The following is a description of a gene set: Genes containing one or more binding sites for (Sall1) in their promoter regions (TSS -1000,+100 bp) as identified by GTRD version 20.06 ChIP-seq harmonization. Mouse Gene Set: SALL1_TARGET_GENES species: Mus musculus from publication Yevshin I, Sharipov R, Kolmykov S, Kondrakhin Y, Kolpakov F (PMID 30445619), and this is the list of marker genes: Gm5464, Vwc2l, Gm14017, Kcnq1ot1, Pde4d, H2ac5-ps, Alyref2, Creb1, Zfp949, Gm22661, Cdkl3, Mir1956, Dppa5a, Setd5, Etv5, Yif1b, Shisa2, Gm28513, B230307C23Rik, Dock9, 1700019D03Rik, Cdk5r1 (NCBI Gene Id 52900), Sall4, Dusp6, Cped1, Hprt1, 1700008O03Rik, Tbc1d23, Fam193a, Gm15290, Magohb, Sucla2, Gm5700, Zfp42, Trio, Gm25152, Gm11627, Pcdhga6, Gm12100, Stum, Fbxo11, Dennd2c, Zfyve9, Ankrd55, Gm15226 (NCBI Gene Id 100041912), Oxct1as, Mbd5, Ncam1, Zfp521, Zfp512, Apela, Srgap3, Zfp600, Kif20b, Mcm6, Smim27, Arid1a, Wdtc1, Gm20609, Cpeb3, Trpm7, Glo1-ps, Prickle1, Pfdn4, Tfdp2, Agk, Slco5a1, Got2, Mtus1, A530020G20Rik, Eci2, Snai2, Nupr1, Zfp608 (zinc finger protein 608), Tubg2, Neil3, Scp2, Gm10044, Art5, Slc25a40, Axl, Pax6, Psmd13, Cdh10, Ddx59, Hnrnpu, Rdm1, Parvaos (parvin, alpha, opposite strand), Cab39, Btf3l4, Commd2, Scg2, Bcl9, Gm12320, Fis1, Tbc1d9b, Tcf4 (transcription factor 4, NCBI Gene Id 67762), Altre, Ankrd35, Zbtb38, Usp44, Ankrd40, Rangap1, Txlnb, Casz1, Rpl5, Mir1894, Zfp516, Leo1, Plekha1, Slc25a5, Fundc2, Rimoc1, Spmip7, Qdpr, Lmbrd1, Fbxo36, Clec2d, Cyp2j6, Atp5mc1 (NCBI Gene Id 11951), Pnpla8, Fndc3a, Ucp2, Pxk, Rbm47, Wnk3, Nqo1, Gm22788, Rnf125, Olig3, Wls, Ift46, 4930453N24Rik, AI115009, Atad2b, Vldlr, Kat6a, Rif1, Adgra2, Fut10, Dnpep, Afg1l, Abcg2, Fsbp, Slc13a2, Smarcd3, Tgif1, Zfp148, Zfp760, H3c2, Arl6ip5, Ldha, Tenm3, Sh3tc1, Zfp568, Tyro3, Cenpb, Hsp90aa1, Gys1, Gm8596, Gm12676, Zfp182, Slc43a1, Fubp1, Cep41, Mir7671, Ambra1, Meis2, Spp1, Mir6352, Gm23946, Plcxd3, Wnk1, Frmd4b, Prrc2a, Gm11518, Tnfrsf11a, 5830487J09Rik, Atf6, Kics2, Gm26907, Gm15706, Gm650 (predicted pseudogene 650), Tcea3, Utp14b, Cox7a1 (NCBI Gene Id 12865), Rnu1b2, Trip4, Dapp1, Cast, Elavl4, Irak2, Gm11346, Prrt1b, Apc, Cog3, Atp7a, Shb, Gm11827, Ccdc162, Map4, Eif4e, Lmo1, Tjp2, Prune1, Sox2ot, Phc1, Npc1, Slf2, Mir6380, Slc12a2, Snx17, Itpka, Ercc4, Mast2, Eml5, Cpsf6, Gm11198, Gm12366, Tomm40l, Chd9, Stxbp3 (syntaxin binding protein 3), Gnai2, Morc2b, Slc35f2, Nfia, Itga6, Slc8b1, Atxn7l1 (ataxin 7-like 1), Usp7, B230112J18Rik, Vkorc1, Snora61, Dpysl3, Tmbim4, Fam185a, Gm13586, Nr5a2, 4930445N18Rik, Sfrp1, Chrna9, Nid2, Klhl5, AA474408, Eddm13, Evi5, Htr2b, 1700021F02Rik, Hpgd, Eif3e, Abca8b, Glrx2, Klf3, Zbtb18, Fcor, Jade1, 4921514A10Rik, AW551984 (NCBI Gene Id 244810), 4930535E02Rik, Prr13, Elobl, D830025C05Rik, Tti2, Spats2l, Mir367, Dnah14 (NCBI Gene Id 381311), Trim13, Hook2, Eif4g1, Stmn1, Pot1a (NCBI Gene Id 69016), Mrpl13, Tanc1, Polg, A930012O16Rik, Dst, Ppp1r2-ps1, Sh3gl1, Pml, Acox1, Ifit2, Gm53, Camk1d, Ppp1cc, Hormad2, Ticrr, Gm6283, 1700020L13Rik, Atg14, Gabpb2, Arf4 (NCBI Gene Id 30916), Dcp1b, Ackr3, Mxi1, Mrpl39, Fbxo15, 3222401L13Rik, Bcl6, Mrpl11, Mbnl1, Gm20604, Gm867, Tmem253 (transmembrane protein 253), Ripk1, Zfp958, Sec24b, Gm23613, Rsrc1, Tmsb10, Pcmtd1, Mnat1, Abcc10, Yars2, Cand1, Ylpm1, Sp3, Gnpnat1, Vegfc, Hscb, Fetub, Prp2rt, Slc25a53, Mettl2, Apold1, Prmt6, Tbx3, Lmo4, Ston1, Tmem220, Ccnc, Mir302a, Prorsd1 (prolyl-tRNA synthetase domain containing 1), Nt5m, Apoo, Gm22779, Rbmx2, Sertad2, Rras, Gm20655, Med18, A730036I17Rik, Mras (NCBI Gene Id 73053), Setd2, 2410137M14Rik, Gm11335, Rbbp7, Phip, Ptch1, Rpe, Nf1, 9530068E07Rik, Emx2, Gm23596, Rev3l, Cilk1, Clcn3, AU040972, 2210417A02Rik, Elapor1, H2-T24, Upp1, Mir125b-1, Peg10, Trp53cor1, Atp9a, Urgcp (NCBI Gene Id 72046), Slc25a12, Rpgrip1, Mab21l3, Magt1, Maf (NCBI Gene Id 78336), Pds5a, Pelp1, Mir302d, Mylpf, Nop58, Foxp1, Gm26562 (NCBI Gene Id 105246095), Mtf2, Rapgef2, Rmc1, Anapc5, Hsp90ab1, Prdm1, Mindy2, C1rl, 1700023G09Rik, Platr14, Mir6347, Zdhhc18, Zfp595, Rabgap1l, Atp10d, Nrip1 (nuclear receptor interacting protein 1), Dppa4, Pdgfd, Snhg12, Slc12a6, 9030622O22Rik, Clec12a, Gm17057 (predicted gene 17057), U2surp, Gprc5a, Suco, Ank2, Tns3, Dusp19, Hoxaas3, Smim18, Fbxo5, Efna1, Cntnap3, Tmem11, Tmem131l, Cripto, Ak4, Gm26901, 4930439D14Rik, Gas2, H2ac11, Ect2, Pdzk1, Rbpj, Prmt3, Cop1, Dhx57, N4bp2l2, Ywhah, Polr3g, 1700010H22Rik, Ppp3r1, 2700038G22Rik, Elovl6, Plekhb1, Rsl24d1, Ccdc68, Abl2, Mat2b, 9330185C12Rik, Shcbp1l, Bard1, Pikfyve, Plcb4, Gm12059, Vps50, 2310069B03Rik, Gm26703, Esrrb, Mpc1, Pus10, Gm13474, Luc7l2, B530045E10Rik, Platr22, Atg13, Hmgn2-ps, Hus1, Usp22 (ubiquitin specific peptidase 22), Rnf8, Tpd52, Psmc6, Gm9050 (predicted gene 9050), F13b, Trav6-3, Sh3bgrl, Avl9, Mlh3, Sbds, Slc30a7, Frem1, Cops7b, Gsr, Mpzl1, Rpf1, Tcf7l2, Gm14210, Tmem38b, Pard3, Rerg, Tbc1d4, Setdb1, Syndig1, 1700071M16Rik, Tyw1, Gm13349, Asxl1, Skida1, Ifitm1 (NCBI Gene Id 68713), Sash1, Scarna2, Gm12795, Mup6, Tdh, Npm3-ps1, Kis2, Pex13, Tnfaip6, Tbrg1, Zfp3, 4833439L19Rik, Cox16, Armcx1, Snurf, 2900041M22Rik, Aim2 (NCBI Gene Id 383619), Ptprz1, Slc29a1, Gm8210, Zfp207, Gm24031, Gm3329, Sec61a2, Gm4984, Porcn, Gm16551, Cebpzos, Tnnt1, Apol7a, Arl14ep, Akr1c19, Gfer, Mir124a-1hg, Smarca5, Slc23a2, Tuba1b, Btf3-ps2, Ctbp2, Spag9, Nrg4, Borcs5, Med1, Armc9, Dhx32, Egfros (epidermal growth factor receptor, opposite strand), Mkrn2, Zfp74, Mir9-2, Ppp1r9a, Trerf1, F8, Pbx2, Gm12974, Gm26744, Elf1, Gid8 (NCBI Gene Id 98980), H60b, Gm11517, Clk4, Plet1, Bcat1, Col25a1, Tmed7, Zfp710, Marf1, Ndst3, Nfyc, Fh1, Slc35d2, Ccdc177, Sox11, Nuggc, Platr10, Ino80dos, Or8b49, 2410021H03Rik, Tm2d1, Actl6a, 2010204K13Rik, Cdiptos, Rarg, Ncor1, Gm11960, Otop1, Epb41l5, Gm10224, Ank3, Gimap9 (GTPase, IMAP family member 9), Gm17501, Tle4, Sycp2l, Arhgef12, Trim6, Slc37a2, Atg2a, Halr1, BC048507, H2ac8, Rnf157, Sms, Ubqln2, Lrp2, Clcc1, Impa2, Ubb, Trim34b, Mdm4, Lockd, Ttc33, Snord3b-ps2, Ino80d, Eps15, Dlg1, Angpt2, Gm4895, Slc6a6, Rpl24, Ipo11, Itpk1, Rev1, Gm19710, Pttg1, Aasdh, Fbln5, Zmym1, Pabpc4, H3c11, L1td1, Usf3, Akt3, Mir3098, Mcm5, Pcdhgb5, Gm2541, Hnrnpdl, Dab2ip, Xpa, BC004004, Otud5 (NCBI Gene Id 54644), Mcc, Dtl, Gm11496, Arpc3 (actin related protein 2/3 complex, subunit 3), Pfkfb4, Clk1, Zfp791, Kras, Dbf4, Abt1, Fbxl17, Xkr8, Dcun1d3, Rny3, Rps23rg1, Mogat1, Gm33366 (predicted gene, 33366), 1700031A10Rik, Jag1, Cep112, Aebp2, Il1rl2, Myrf, Trps1, Rdh10, BC046401, Nus1, Commd4, Hax1, Il17rd, Mobp, Pik3r4, Pcdha6, Omg, Klhl34, Acot7, Mc5r (NCBI Gene Id 17203), Gramd1a, 4933431K14Rik, Arhgef25, Adar, Adam5, Nup205, Micu1, Mrm2 (mitochondrial rRNA methyltransferase 2), Dnajc21, Gm13736, Tnrc18, Spin4, Mir1983, Gm12514, H2bc8, H2az2, Gm24335, Gm16041, Tmem117, Scpep1, Aff1, Rbm25, Zkscan5, 2810402E24Rik, Tcaf2, Gm28043, 5330429C05Rik, Nup35, B3gnt5, Gm24432, Chek2, Abi1, Snapc5, Zfp36l1-ps, Epha3, Atxn1, Gm29630, Rusc2, Astn1, Plekha4, Acss1, Akap13, Chac2, Gm7244 (predicted gene 7244), Fah, Usp45, Jade3, Katnbl1, Smyd3, Eif4e1b, Nras, Mageb16, Pbld2, Aldh18a1, Hnrnpk, Oas1g, Gm16318, Pwwp2a, BB557941 (NCBI Gene Id 767815), Platr9, H4c1, Tpp2, Gm16876, Septin1, Asic5, Gm807, Mymx, Tsix, Gm15710, Arhgap28, Birc2, Gm9916, Bicd1, Pgk1, Gm2093, E130006D01Rik, Rps26, Map2k6, Eid2b, Tle5, Cep170, Ccna2 (cyclin A2), Cntnap2, Rnasel, Atp8a1, Plpp1, C920006O11Rik, Rpl9-ps2, Gm26671, Snx12, Tmem260, 4931440P22Rik, H3c4, Stx3, Gm22973, Arhgap18, Nup85, Gm23143, Cyp27a1, Krtap5-21, Gm14133, Rpl23, Senp3, Matr3, Pla2g10, Mir290a, Zfp345, Dpp8, Poln, Gm22777, Acadm, D16Ertd472e, Nkapl, Shroom2, Gm12925, Cmklr2, Haus3, Fbxo27, Syngr1, Nt5c3, Flrt3, Sema4d, Fam98a, Wsb2, Frmd5 (FERM domain containing 5), Pgap1, Dnajc13, Zmynd8, Ly75, Mme, Trim26, Gm25918, Uba2, Anp32e, Mettl17 (NCBI Gene Id 69637), Zfp560, Lactb2, Zc4h2, Itgbl1, Slc7a3, Ppfia3, Gm36638, Mcph1, Zbtb33, R3hdm1, Cerkl, Hlf, Creb3l2, Adgrl1, Mindy1, A830008E24Rik, Mir302b, Kansl1, Nucks1, Cox15, Tex14, Rictor, Ogt, Cxcr3 (C-X-C motif chemokine receptor 3), Tpd52l1, Zfp532, Cox6b1 (cytochrome c oxidase, subunit 6B1), Slc19a3, Zfp1004, Gm10827, Cdc73, Stk38 (serine/threonine kinase 38), Pramel13os, Gm20033, Gm14024 (predicted gene 14024), Zscan26, Platr11, Snx1, Pir, Nfe2l1, Cfap276, Ssc4d, Pcdha1, Rnf103, Tomm5 (NCBI Gene Id 68512), Wdr76, Lrrc49, G2e3, Gm14393, BC065397, Cd300lg, Gm12882, Gsta4, Snrpn (NCBI Gene Id 20646), 1700013N06Rik, Abl1, Gm2824, Parp2, Rbm39, Cited2, Esrrg (estrogen-related receptor gamma), Jarid2, Macf1 (NCBI Gene Id 97195), Gm8503, Hspb1, Ywhae, Sulf1, Schip1, Liph, Pkp4, Fgd4, Zfp60, Prkci, Dgkeos, Nop10, Hbegf, Glra3, Elf5, Gm23105, Mvb12b, Arhgap21, Psmb6, Gm9929, Gm25336 (predicted gene, 25336), Cndp2, Cdca2, Snord13, Kdm1a, Suclg1, Plekha2, Ypel1, Otx2, Tstd3, Calr4, Mir124a-1, Srrm2, Vpreb1a, Fkbp5, Gm16348, Vstm2a, Edn1, Vps35l, A230060F14Rik, 1700120B22Rik, Mllt11, Megf8, Lrpap1, Top3b, Cxxc4, Klhdc10, Kcna7, Mir6896, Tsr2, Cep120, Snord99, Fbxo10, Jmjd1c, Fbxo47, Nepro, Spred1, Ppef2, Emc9, Vangl1, Elmo1, Homez, Rps10-ps2, Osbpl9, Nphp3, 2210016L21Rik, Gm2287, Hmgxb4, Eya1, Tmem39a, Lrrc34, 1700066J03Rik, Ifitm5, Ptpn22, Nudt1, Foxn3, Gpr19, Fry, Idh1, Ifi35, Gm16222, Gm15040, Cdkn1a, Armcx4 (armadillo repeat containing, X-linked 4), Neil1, Hnrnph3, Bpnt1, Gm17929, C1ra, Gm42922, Ubl3, Tet2, Gpr21, Cald1, 4632427E13Rik, Gm2559, Cenpi, Fancd2os, Gm23011, Wrap53 (NCBI Gene Id 216853), Csrnp3, Dcdc2a, Polr1f, Dhx9, Park7, Csgalnact1 (chondroitin sulfate N-acetylgalactosaminyltransferase 1), 2700078F05Rik, Zhx2, Gm5915, Myef2, Il33, Adipor2, Dnm2, Irgm1, Gm17764, Fam169b, Rad54b (RAD54 homolog B (S. cerevisiae)), Tcte2, Cfap53, Dnajb4, Ly6g6e (NCBI Gene Id 70274), Gm14261 (predicted gene 14261), Gm24735, Gucy1a2, Gm27042, Ptk2b, Hltf, Glra2, Timm23, Fignl1, C230035I16Rik, Zc3h15, Gm19705, Gm26812, Mrpl33, Gm26479, Gm27219, Fanci, Mir9-2hg, Pgghg, Gm16794, Stat3, 2500004C02Rik, Igf2bp1, Cacna2d4, Meg3, Nub1, Srrm3os, Gm15781, Lpar6, Oacyl, Zfp57, Pgap2, Fig4, Trex1, Mycn, Cfap161, 4930519P11Rik, Pcf11, Hecw2, Utp3, Isl1, Tceal9, Mir7055, Bclaf1, Gm8580, 5033430I15Rik, Eef1a1 (NCBI Gene Id 13627), Spta1, Cdk2ap1rt, Ythdc1, Mir302c, Ncoa3 (nuclear receptor coactivator 3), 1110002J07Rik, Wdr5b, Hdac9, Nnt, Fgf13, Gm24128, Magi2, Ube2e1, Cd9, Adamts10, Aanat, Sppl3, Gm5535, Zfp952, Rbm28 (NCBI Gene Id 68272), Tm7sf3, Xiap, Slc35g1, Spg11, Ipmk, Mars1, Tmem231, Tfrc, Dusp12, Nifk, Lix1, 4930579D09Rik, Mir8120, Pou6f1, Selenop, Ccser2, Arih2, Gm3716, Rabgap1, St7, 1700067G17Rik, Zfp219, Ctps2, Chd4, Nufip2, Pde7a, Morc1 (NCBI Gene Id 17450), Gm25857, Myadml2 (myeloid-associated differentiation marker-like 2), 1700028E10Rik, Slc6a15, Tia1 (cytotoxic granule-associated RNA binding protein 1), Gm16249, Lasp1, Gm13853, Zfp746, B230119M05Rik, Rab30, AY512931, Zfp106, Dock10, Acsl3, Ssr2, Gm25502, Srpk1, Platr7, Abcb8, Phyh (NCBI Gene Id 98889), Zfp143, Enah, Cfap43, Gm22739, 2610037D02Rik (NCBI Gene Id 75768), Rims1, Cdh6, Cyyr1, Zfp810 (zinc finger protein 810), Cbx5, Atf7ip, Scamp1, Gm16283, 4930461G14Rik, Ccdc171, Izumo2, Fryl, Slc39a13, Saa3, Trim12a, Sgk1, Bclaf3, Myo10 (myosin X), Etv1, Dcaf10, Celrr, Hsd17b11, Etl4, Hoxd8, Gm26632, Defb30, Luzp1, 5031434O11Rik, Rbfox2, 1700057H15Rik, Atf1, Gadd45g, Fbxl3, Igf2bp3, Ankrd6, Trim71, Gm8186, Ube3c, Cyb5r1, Efr3a, Nox4, Mtbp, Uba1, Zfp592, Ctcf, Gabarapl2, Or11a4, Kcnj8, Gm13529, Gjc1, Lmo7, Emb, Ackr4, Irak3, Nab2, Alg8, Papola, Hcn1, Spns1, Coro2a, Lrrtm3, Snrpd1, Spry1, Chd2, Dok2 (docking protein 2), Arid2, Gm15583, Cnpy1, Adgrb3, Tph2, Gmfb, Trip12, Gm13415, Cnnm1, Cdhr18, Fam169a, Timp1 (NCBI Gene Id 21857), Gm35986, Gm13629, Satb1, St6galnac6, Creb3l1, Znrf1, Ralgps2, Dmtf1, Exph5, Mllt3, Syp, Nhsl1, Boll, Slc27a2, Nnmt (NCBI Gene Id 18113), Tmem191, Gm25394, Gm11528, Dpf3, Wdr91, Pcdhb18, Tph1, Zeb2, Poldip3, Ssbp3, Fam221a, Fgfr1, B130011K05Rik, Zdhhc21, C430039J16Rik, Fem1a, Gcnt2, Dcst1, Adamts6, Cox17, Aloxe3, Fam90a1b (NCBI Gene Id 74432), Marcks, Sypl2, Spry4, Gm43568, Gjb3, Nfat5, Fstl5, Ptges3-ps, Gm17976, Morf4l2, Defb1, Rhbdl2 (rhomboid like 2), Asnsd1, Dhx16, Nme1, Cdipt, Rnu11, Gm25899, Gm16892, Gm36070, Sun1, Pakap, 2410017I17Rik, Ddc, Mreg, Gdf3, Pfn1, Ncapd2, Bbs2, Gpt2 (NCBI Gene Id 98512), Cep164, Gm6686, Gm973, Sox21, Iars1, Eif3f, Platr26, Clasp2, Spic, Qser1, Dppa2, Rragc, Gm14401, Mir670hg, Srrm4os, Wapl, Alg13, Tesk2, Osbpl1a, Rnf135, Mtcl1, Ebi3, Gm11747, Zeb2os, Trim33, Mfsd4b5, Lsm2, Gm22353, Mrpl58, Plin2, Zfp607b, Zc3hav1, Rhoq, Rnf7l, Rab27a, Hmgb1-ps6, Cept1, Pot1b, Fut9, Tmem156, Tcf12, Nek7, Ddo, Rps29, Birc6, Opa1, Rtn1, Rsbn1, 4930478M09Rik, Eif4h, Cdk19, Mir1929, Hectd2os, AW146154, Fubp3, Zfp609, Tcl1, Dnajc6, Palld, Pfkp, Cdc14b, Cpne8, Cfap221, Mov10, Cdk6, Pbx4, Ints13, AU018091, Xrn1, Ripply1, Frrs1, 1700028I16Rik, Scn2a, Eogt, Arhgef26, Ebf1, Nfib, Otud4, Prickle2, Kctd4, Ctdsp1, Dlg5, H2af-ps2, Gm16096, n-R5s185, Mir101a, A930018P22Rik, Mt2, Cox7a2, Tsc22d1, Rgs19, Apobec1, Fbxw7, Dpy19l1, Gm25054, Fan1, Nbr1, Pipox, Wtap (WT1 associating protein), Sbno1, Hnrnpd, Rapgef6, Zup1, Slc7a7, Gabpb1, Psap, H2bc7, Dhrs7, Adam32, Tead1, Slc1a5, 4930442L01Rik, Trim34a, Gm24143, 4732419C18Rik, Fyttd1, Sh3kbp1, Mif-ps6, Rcc2, Gm27252, Srrm3, Gpx7, Pou2f1 (POU domain, class 2, transcription factor 1), Sgce, 5930403N24Rik, Arhgap26, Xrcc5, Wdr64, Zfp961, Zbtb20, 4833407H14Rik, BC028471